The following is a description of a gene set: studied in species Mus musculus This event has been computationally inferred from an event that has been demonstrated in another species.<p>The inference is based on the homology mapping from PANTHER. Briefly, reactions for which all involved PhysicalEntities (in input, output and catalyst) have a mapped orthologue/paralogue (for complexes at least 75% of components must have a mapping) are inferred to the other species. electronically inferred by orthology from the curated human pathway Reactome Pathway: PERK regulates gene expression part of: Unfolded Protein Response (UPR), and this is the list of marker genes: Eif2s3x, Eif2ak3